Given this list of marker genes Hsp90b1, Sae1, Myh6, Hspa8, Rfc1, Helz, Atf7ip, Myh2, Smc1b, Kif3a, Atp7b, Dnajc24, Acss1 (acyl-CoA synthetase short-chain family member 1), Kif1a, Dnajb1, Dnai2, Eif4a1, Ddx27, Lonp1, Recql, Ercc6l2 (NCBI Gene Id 76251), Cenpe, Atp5mg, Clpx, Rfc5, Nsf, Tap2, Myo7a, Slfn9, Entpd7 (NCBI Gene Id 93685), Cdc6, Katnal2, Mtrex, Ddx51, Atp5f1c, Ntpcr, Myh14, Actc1, Setx, Ep400, Mcm3, Ddx31, Dscc1, Abcc8, Uba7, Helb, Zgrf1 (NCBI Gene Id 99630), Ddx17, Top2a, Tomm20, Tnnt2, Kif19a (kinesin family member 19A), Dnah9, Hspa1a, Dhx35, Atp13a1, Abcc9, Chtf8 (CTF8, chromosome transmission fidelity factor 8), Abcb5 (ATP-binding cassette, sub-family B member 5), Myo9b, Dna2, Nav3, Ide, Dnah12, Rab3a, Atp4b, Kif5b, Abca16, Atp6v1c2, Nkrf, Kif28, Afg3l1, Ddx25 (NCBI Gene Id 30959), Acsm5, Ythdc2, Nav1, Shoc1, Kif2a, Ddx50, Dnah2, Rfc3, Atp6v0a2, Zranb3 (NCBI Gene Id 71112), Pms1, Dnah5, Atp2b3, Smc6, Abcb8, Nae1 (NEDD8 activating enzyme E1 subunit 1), Orc1, Myl6, Myo6, Rad51c, Bag3, Mre11a, Hfm1, Fignl2, Atp8b3, Atp1a1, Dnajb6, Cct6b, Agrn, Fign, Ddx52, Myh1, Smarca5, Ddx3y, Actb, Morc4, Znfx1, Dhx38, Spg7, Acsl3, Atp13a3, Myo1g, Atp6ap1l, Hspa14, Atp6v0a4, Abcg5, Ddx18, Pln, Ddx4, Rab6a, Myo10, Myo5b, Rad51b, Grpel2, Atp6v0d2, Hspa13, Atp2c2, Dhx57 (NCBI Gene Id 211921), Dhx58, Kif3c, Kifc3, Smarca4, Orc4, Ddx20, Trip13, Dnaja2, Mcm8, Myo3b, Hsph1, Msh5 (NCBI Gene Id 279936), Dync1li1, Cct4, Iqca1, Dnajb2, Atp1a3, Myh13, Abca8b, Mfsd2a, Myo7b, Katnal1, Hltf, Abcb11, Abcd4, Abcc3, Chd6, Atp5pf, Uba5, Smc3, Dnaja1, Hsp90aa1, Kif2c, Rab4a, Slc27a6, Kcnj8, Mlh1, Hspa5, Rnf213, Mcm2, Smc4, Acsf2, Kif1c (NCBI Gene Id 237826), Cpox, Cct5, Atp2b1, Acss3, Aqr, Vwa8, Slc27a4, Atp6v1g3, Atp5f1d, Tor3a, Atad3a, Aacs, Rad54b, Eif4a2, Dhx9, Xrcc3, Abca7, Dnah7a, Msh6, Kif12, Nubp2, Helq, Atp2a2, Kif22, Kif18b (NCBI Gene Id 70218), Nvl, Morc2b, Uba2 (ubiquitin-like modifier activating enzyme 2), Kif26b, Myo1b, Alpl, Afg1l, 2310057M21Rik, Ddx39b, Cct6a, Myo9a, Shprh, Pfn2, Mcm6, Ifih1, Afg2b, Bptf, Dqx1, Mmaa, Hspa4l, Abcd3, Dicer1, Kif3b (kinesin family member 3B), Atp11b, Clpb, Dync2h1, Atp6v0d1, Myo1d, Msh3, Psmc6, Btaf1, Ddx47, Psmc3, Dnah1, Atp1b3, Cct2, Kif1b, Recql4, Atp6v0a1, Dnah7b, Kif13a, Chtf18, Mcm9, Afg2a, Polq, Spo11, Kif6, Ipo8, Atp6ap1, Hspa9, Hspa2, Abcg8, Chd2, Wrn, Atp4a, Ino80, Xrcc2, Atp6v0b, Ahsa1, Nubp1, Atp6v1h, Myd88, Fignl1, Pif1, Vcp, Atp11c, Bcs1l, Myo5c, Fbh1, Chd9, Atp8b1, Dhx33, Slfn8, Dhx37, Wrnip1, Abcd2, Msh4, Srcap, Chd1l, Smarcal1, Myo15a, Ercc3, Atp9b (NCBI Gene Id 50771), Abcc1, Hspd1, Vps4b, Fnip2, Dnajc10, Abcg3, Smarcad1, Ralbp1, Atp6v0e, Dnhd1, Atp1b1, Macf1, Kif19b, Slc27a3, Smc2, Snrnp200, Atp5pb, Abcb9, Abcg1, Abcc10, Abca14, Nlrp1b, Top2b, Abca3, Nubpl, Abcb6, Wapl, Atp10b, Atp2a3, Slc27a2, Abca8a (NCBI Gene Id 217258), Myo1f, Mov10l1, Kif16b, Atp2a1, Atp13a2, Ddx28, Top6bl, Rad54l, Atp5f1a, Myo1c, Atp5f1e, Myh10, Abcc2, Kif20b, Abcg2, Abca1, Rad51, Clpp, Dnah7c, Abca2, Cftr, Acsm4, Recql5, Dnajb4, Nlrp3, Chd1, Uba1y, Atp6v1a, Myh9, Rigi, Atp10d, Kif21b, Abcf1, Acsm2, Atp5f1b, Rtel1, Kif14, Smchd1, Morc2a, Kif7, Psmc5, Mcm7, Rad50, Fnip1, Chd7, Atp5if1, Mcm4, Psmc1, Abca17, Hells, Hsp90ab1, Entpd2, Atp11a, Ddx39a, Kif2b, Mov10, Atp6v1f, Ercc2, Pex1, Ighmbp2, Myh4, Dhx8, Abca12, Chd3, Dnajc15, Fancm, Atp13a5, Kif17, Tmem94, Abcc12, Carns1, Ruvbl2, Ddx19a, Gtf2f2, Kif5c, Ddx21, Smarca2, Nlrp10, Atp2b4, Eif4a3l1, Ddx6, Kifc5b, Atp6v0c, Tor1a, Pex6, Trap1, Acsm3, Atad5, Ddx56, Dhx32, Dhx34, Ddx19b, Rfc4, Smc1a, Anxa1, G3bp1, Atad1, Atp6v1b1, Chd4, Dnah10, Tor4a, Hyou1, Blm, Afg3l2, Ahsa2, Atp13a4, Kif20a, Stard9, Atp6v1e1, Dnah17, Gpn1, Abcb1a, Acsbg1, Eif4a3, Hspbp1, Bag4, Ddx59, Ddx42 (DEAD box helicase 42), Smpdl3a, Myo5a, Atp1a2, Sil1, Arid1a, Gtf2h4, Ddx43, Tsc1, Sub1, Swsap1, Nav2, Grpel1, Katnb1, Myo3a, Hspa4, D1Pas1, Uba6, Ascc3, Abca4, Iqca1l, Srp54a, Ddx55, Ddx54, Ddx5, Brip1, Cct7, Npm2, Morc3, Kifc1, Get3, Ddx46, Abcc4, Myo1h, Kif21a (kinesin family member 21A), Mlh3, Srpra, Acsbg2 (acyl-CoA synthetase bubblegum family member 2), Upf1, Xrcc5, Kif27, Ddx1, Dnah6, Ttf2, Dhx36, Hscb, Atp6v1d, Atp8a1, Slc27a1, Psmc4, Acsm1, Dync1h1, Vps4a, Tor1aip1, Tor1aip2, Dnah11, Acsl4, Kif5a, Bag5, Atrx, Abca13, Abcb4, Cecr2, Ddx49, Helz2, Twnk, Acss2, Kif15 (NCBI Gene Id 73146), Abcb7, Rhobtb3, Nlrp1a, Atp10a, Abcf3, Ddx10, Dync1i1, Myh11, Ddx24, Tdrd9, Kif11, Acsbg3, Skic2, Dhx40, Atp8b5, Smarca1, Lonp2, Ddx41, Rad54l2, Abcg4, Kif26a, Chd5, Tor2a, Myo19, Ruvbl1, Ddx11, Atp6v1c1, Atp2c1, Myh3, Entpd1, Myh7, Pfn1, Anxa5, Kif13b, Abcd1, Atp6v1g1, Bag1, Myh8, Abcf2, Dnah3, Atp6v1b2, Kcnj11, Rbbp4, Pms2, Kifc2, Acsf3, Ercc6, Acsl5, Abcb1b, Eif4a3l2, Abcc6, Atp7a, Acsl1, Abca5, Kif24, Abcb10, Cct8, Mcm5, Abcc5, Xrcc6, Atp6v1g2, Atp8a2, Tcp1 (NCBI Gene Id 435546), Katna1, Ola1, Uba1 (NCBI Gene Id 22201), Tmem30a, Spast, Rad17, Cdk7, Rfc2, Hspa1l, Myo1e (myosin IE), Atp1b2, Abca9, Atad2, Tdrd12, Atp6v0e2, Kif23, Atp8b2, Dnah14, Myh15, Msh2, Slc27a5, Bag2, Dnajc19, Trp53, Atp2b2, Dhx29, Abca6, Abce1, Abca15, Atp6v1e2, Supv3l1, Ercc6l, Ak6, Dmc1 (DNA meiotic recombinase 1), Dhx15, Kif18a, Uba3, Kif9, Psmc2, Chd8 (NCBI Gene Id 67772), Cct3, Atg7, Atp9a, Yme1l1, Atp5po, Dhx30, Tap1, Myo1a, Clu, Atp8b4, Atad2b, Mocs3, Dnah8, Atp1a4, Rad51d, Myh7b, Tmem30b, Ddx3x, Dhx16, Tor1b, Atp12a, Acsl6, Kif4, Hspa1b, here is a description of the gene set: A molecular function characterized by the coupling of ATP hydrolysis to other steps of a reaction mechanism to make the reaction energetically favorable, for example to catalyze a reaction or drive transport against a concentration gradient. Mouse Gene Set: GOMF_ATP_DEPENDENT_ACTIVITY studied in species Mus musculus